Given this list of marker genes CCM2L, RSL24D1P6, RPL7AP14, RN7SL237P, ACTL10, DUX4L35, FDX1P1, CEP250, RNU4-40P, BPIFB1, LINC00489, FAM83D, BPIFB5P, ENSG00000212134, MYH7B, RN7SL156P, RNA5SP532, RNU1-94P, ACSS2, CDC42P1, AHCY, SNHG17, CFTRP3, DEFB123, FRG1DP, BPIFB2, RNA5SP480, MIR3193, DLGAP4-AS1, REM1, MTCL2, AGGF1P10, SNHG11, ENSG00000260257, RNU6-407P, HAUS6P2, ATP5MFP7, SLA2, HM13, C20orf173, SRC, TTI1, RALY, ZNF285DP, KIAA1755, HNRNPA3P2, GSS, NOL4L, ABALON, PIGPP3, ASIP, BPIFA3, MIR1825, DLGAP4, DEFB121, MIR499B, MIR4755, ENSG00000283568, COX7BP2, DUX4L34, SAMHD1, NOL4L-DT, LINC01597, PIGU, SUN5, ENSG00000283291, PHF20, DUX4L37, CHMP4B, EPB41L1, NCOA6, RBM12, NDRG3, ENSG00000274385, BPIFB9P, CDK5RAP3P1, NFS1, MYLK2, BCL2L1, FAM242B, FRG1BP (FSHD region gene 1 family member B, pseudogene), EPB41L1-AS1, EIF6, RALY-AS1, TPM3P2, TLDC2 (TBC/LysM-associated domain containing 2), DEFB115, ERGIC3, MANBAL, RPL31P3, CDK5RAP1, RPS2P1, GHRH, DUX4L33, TGIF2-RAB5IF, DEFB122, RPS3P2, PLAGL2, SNORA60, ITCH, FRG1EP, MIR548O2, TM9SF4, ENSG00000296538, ZNF341-AS1, EIF2S2, PXMP4, CFTRP2, NPM1P19, ID1, MYL9, SOCS2P1, MIR644A, DENRP1, UQCC1, ZNF341, BAK1P1, SLC32A1, BPIFA4P, ACTR5, RBL1, FER1L4, PPIAP3, DEFB124 (NCBI Gene Id 245937), DEFB119, RARRES2P11, DYNLRB1, CDC27P3, DEFB118, RN7SL116P, MT1P3, RPL31P2, BPIFA1, RNU6-384P, DEFB117 (defensin beta 117 (pseudogene)), C20orf144, RBM39, RPS3AP3, FOXS1, CBFA2T2, XKR7, BPIFA2, TGIF2, ITCH-IT1, TTLL9 (tubulin tyrosine ligase like 9), SPAG4, RPL12P3, TGM2, SNORA71A, RPS27AP3, FAM242A, EFCAB8 (EF-hand calcium binding domain 8), RAB5IF, DEFB116, ANKRD20A21P, E2F1, CPNE1 (NCBI Gene Id 8904), NECAB3, AAR2, RNU6-759P, LBP, RNA5SP483, HMGB3P1, SNORA71C, ENSG00000275877, XPOTP1, BPIFB3, TRPC4AP, TPX2 (TPX2 microtubule nucleation factor), EDEM2, GLRXP1, NNAT, POFUT1, RNA5SP528, DUX4L32, PCMTD1P7 (NCBI Gene Id 107080553), HCK, RN7SKP185, ITCH-AS1, BPI, DSN1, MAP1LC3A, SNORA71B, COMMD7, ARHGAP40, RNU6-937P, PUDPP3, DHX35, ADIG, ENSG00000297212, BPIFB4, NORAD, MCTS2, GDF5-AS1, RPF2P1, CTNNBL1 (NCBI Gene Id 63927), VSTM2L, SCAND1, COX4I2, CEP250-AS1, FRG2EP, BCL2L1-AS1, RNA5SP482, ASXL1, SNORA71, DUSP15, RPRD1B, FAM83C, PPP1R16B (protein phosphatase 1 regulatory subunit 16B), PDRG1, SNTA1, SNORA71D, HIGD1AP16, MROH8, RPL36P4, FRG1CP, MAPRE1, RALGAPB, KIF3B, FAM83C-AS1, ENSG00000277301, ENSG00000204117, MIR499A, MLLT10P1, LINC01746, RN7SKP173, CNBD2, ENSG00000201151, HM13-AS1, PROCR, RPL37P1, RNA5SP481, RN7SKP271, ROMO1, BLCAP (NCBI Gene Id 10904), DKKL1P1, BPIFB6, C20orf203, TP53INP2, GDF5, HMGB3P2 (high mobility group box 3 pseudogene 2), HM13-IT1, RPN2, LINC00028, MMP24OS, DNMT3B, GGT7, SNORA71E, DHX35-DT, MMP24, MIR1289-1, here is a description of the gene set: studied in species Homo sapiens Human Gene Set: chr20q11